The following is a description of a gene set: Reactome Pathway: Defective ABCC6 causes PXE part of: ABC transporter disorders The multidrug resistance associated protein (MRPs) subfamily of the ABC transporter family can transport a wide and diverse range of organic anions that can be endogenous compounds and xenobiotics and their metabolites. The multidrug resistance-associated protein 6 (ABCC6 aka MOAT-E) can actively transport organic anions. Defects in ABCC6 can cause pseudoxanthoma elasticum (PXE; MIM:264800), a rare multisystem disorder characterized by accumulation of mineralized and fragmented elastic fibers in the skin, vasculature and the Burch membrane of the eye. studied in species Homo sapiens, and this is the list of marker genes: ABCC6